The following is a description of a gene set: species: Homo sapiens Genes up-regulated in ductal vs lobular carcinoma breast tumor cells. BACKGROUND: Invasive ductal and lobular carcinomas (IDC and ILC) are the most common histological types of breast cancer. Clinical follow-up data and metastatic patterns suggest that the development and progression of these tumors are different. The aim of our study was to identify gene expression profiles of IDC and ILC in relation to normal breast epithelial cells. METHODS: We examined 30 samples (normal ductal and lobular cells from 10 patients, IDC cells from 5 patients, ILC cells from 5 patients) microdissected from cryosections of ten mastectomy specimens from postmenopausal patients. Fifty nanograms of total RNA were amplified and labeled by PCR and in vitro transcription. Samples were analysed upon Affymetrix U133 Plus 2.0 Arrays. The expression of seven differentially expressed genes (CDH1, EMP1, DDR1, DVL1, KRT5, KRT6, KRT17) was verified by immunohistochemistry on tissue microarrays. Expression of ASPN mRNA was validated by in situ hybridization on frozen sections, and CTHRC1, ASPN and COL3A1 were tested by PCR. RESULTS: Using GCOS pairwise comparison algorithm and rank products we have identified 84 named genes common to ILC versus normal cell types, 74 named genes common to IDC versus normal cell types, 78 named genes differentially expressed between normal ductal and lobular cells, and 28 named genes between IDC and ILC. Genes distinguishing between IDC and ILC are involved in epithelial-mesenchymal transition, TGF-beta and Wnt signaling. These changes were present in both tumor types but appeared to be more prominent in ILC. Immunohistochemistry for several novel markers (EMP1, DVL1, DDR1) distinguished large sets of IDC from ILC. CONCLUSION: IDC and ILC can be differentiated both at the gene and protein levels. In this study we report two candidate genes, asporin (ASPN) and collagen triple helix repeat containing 1 (CTHRC1) which might be significant in breast carcinogenesis. Besides E-cadherin, the proteins validated on tissue microarrays (EMP1, DVL1, DDR1) may represent novel immunohistochemical markers helpful in distinguishing between IDC and ILC. Further studies with larger sets of patients are needed to verify the gene expression profiles of various histological types of breast cancer in order to determine molecular subclassifications, prognosis and the optimum treatment strategies. from publication Turashvili G, Bouchal J, Baumforth K, Wei W, Dziechciarkova M, Ehrmann J, Klein J, Fridman E, Skarda J, Srovnal J, Hajduch M, Murray P, Kolar Z (PMID 17389037) Human Gene Set: TURASHVILI_BREAST_CARCINOMA_DUCTAL_VS_LOBULAR_UP, and this is the list of marker genes: AHCTF1, CDH1, CKS2, MEX3C, WASIR1, SLC1A2, EPB41L3, STK4, TTC14, TRNT1, TTC3 (tetratricopeptide repeat domain 3), LAMP2, S100P, ZNF121, GLCCI1, MTFR2, DTL (denticleless E3 ubiquitin protein ligase homolog), ZNF678, RAB11FIP1, CPB1, OSBPL10, BPIFB1, B3GALNT1, H3C2